Given this list of marker genes TMEM54, TAS2R13, SEL1L3, SERPINA1, TRDN, MYO6, EMB, DEK, PDCD6IP, PARP14, SPOPL, MTCL3, MAP3K13, KDM7A, TMEM38B, USP8, EIF5A2, NPAT, FLVCR1, TRIM59, RCC1, ASB14, UBE2D3, CEP135, ADH5, ZNF148, TENM4, MEF2A, BCL2L2, NXPH2, CDK12, TRIM33, HDAC7, ZNFX1, GPALPP1, CCDC73, TXN2, IKZF1, BICC1, LINC01517, ZEB1, ADIPOR2, ALG13, MDM1, ZSWIM6, TTC39B, OGFRL1, DCAF5, ADAM9, SLC6A16, H2AZ2, PDE10A, EDC3, SLIT2, GPX8, ZCCHC2, ZBTB44, ZNF445, STYK1, APPL1, RASAL2, SEPTIN8, RICTOR, CCNG2, ZNF397, EYA1, NEUROD4, DENND6A, FNDC3A, KLF4, BEND4, MOSPD1, FSD2, PRTG, SH2D2A, PPM1L, BICRAL, SLC18A2, AASDHPPT, XPR1, NFAT5, ACVR2B, KLHL18, TMEM237, GABRA1, PSMF1, DYNC2I1, COA3, ANTXR1, EIF5B, PHF20, GCC2, CTDSPL, ZBTB6, CREB5, IGFBP7, R3HCC1L, ZNF37A, ANKS1A, KLHL6, SPTLC2, SLC4A4, ZNF521, ZMAT4, here is a description of the gene set: Genes predicted to be targets of miRBase v22 microRNA hsa-miR-26b-3p in miRDB v6.0 with MirTarget v4 prediction scores > 80 (high confidence targets). species: Homo sapiens from publication Chen Y, Wang X (PMID 31504780) Human Gene Set: MIR26B_3P